The following is a description of a gene set: species: Homo sapiens Human Gene Set: GOBP_NEGATIVE_REGULATION_OF_NEURON_DIFFERENTIATION Any process that stops, prevents, or reduces the frequency, rate or extent of neuron differentiation., and this is the list of marker genes: IRX3, BMP7, FOXO3, ISL2, RAP1GAP, HMG20A, DDX6 (NCBI Gene Id 1656), HOXA2, ZNF536, EIF4E, TP73, DLX2, POU4F2, ID2, NEPRO, TLX3, OLIG2, ASCL1, EIF4ENIF1, GLI3, SHH, CALR, FEZF2, HES1, SHOC2, WNT3A, NOTCH3, DIXDC1, NKX6-3, PHOX2B, HEY1, CTDSP1, CDK5RAP2, SOX2 (SRY-box transcription factor 2), GSK3B, PTBP1, GDF11, SIX3, NR2E1, DLX1 (NCBI Gene Id 1745), JAG1 (NCBI Gene Id 3715), SLC6A4, ID4, MIB1, ASPM, LSM1, SPAG9, DLL1, FUOM, B2M, PBX1, LBX1, TUNAR, ZHX2, LMX1A, SOX8, NOTCH1, ISL1, CNTN4, FOXG1, NKX2-2, CNTN2, SOX9, MED1, GPR37L1, DISP3, HES5, ITGB1, MAG, CNTF, DTX1, MEIS1, PAX6, EIF2AK4, REST, SOX3